The following is a description of a gene set: species: Homo sapiens Adenylate cyclase activating pathway Human Gene Set: REACTOME_ADENYLATE_CYCLASE_ACTIVATING_PATHWAY, and this is the list of marker genes: ADCY2, ADCY9, ADCY5, ADCY8, ADCY7, GNAL, ADCY4, ADCY6, ADCY3, ADCY1